Given this list of marker genes Ghrl, Crh, Gal, Galr1, Tac1, Ecrg4, here is a description of the gene set: species: Mus musculus Mouse Gene Set: GOBP_POSITIVE_REGULATION_OF_GLUCOCORTICOID_SECRETION Any process that activates or increases the frequency, rate or extent of glucocorticoid secretion.